The following is a description of a gene set: The aggregation, arrangement and bonding together of a set of components to form a presynaptic membrane, including any proteins associated with the membrane, but excluding other cellular components. A presynaptic membrane is a specialized area of membrane of the axon terminal that faces the plasma membrane of the neuron or muscle fiber with which the axon terminal establishes a synaptic junction. studied in species Mus musculus Mouse Gene Set: GOBP_PRESYNAPTIC_MEMBRANE_ASSEMBLY, and this is the list of marker genes: Pten, Ptprd (protein tyrosine phosphatase receptor type D), Lrp4, Nlgn4l, Nlgn3, Il1rapl1, Nlgn2, Nlgn1, Nrxn1